The following is a description of a gene set: studied in species Homo sapiens Human Gene Set: chr7q31, and this is the list of marker genes: RNA5SP239, RNF133, CPED1, HYAL6P, GTF3AP6, RNF148, RNA5SP240, PNPT1P2 (polyribonucleotide nucleotidyltransferase 1 pseudogene 2), ASZ1, ZNF800, LAMB4, FOXP2, ENSG00000241345, PIGCP2, AASS, TPM3P1, CYCSP19, THAP5, CAV2, LINC02830, MIPEPP1, FAM3C, MTND5P8, WNT16, MIR3666, NDUFA5, ZNF277, ANKRD7 (ankyrin repeat domain 7), SLC26A3, HRAT17, LINC01392, LYPLA1P1, LAMB1, EIF3IP1, RNU7-154P, MIR592, TES, BUB3P1, GRM8-AS1, RNU6-581P, RNU6-517P (NCBI Gene Id 106479795), LRRN3, FEZF1-AS1, DOCK4-AS1, SNORA25B, ENSG00000219445, GPR37, RPL3P8, LSMEM1, HYAL4, MTND4P6, POLR2DP2, CAV1, MIR6132, LSM8, DNAJB9, TMEM229A, ENSG00000237813, FEZF1, ANKRD49P4, ENSG00000288634, LINC03043, ENSG00000289578, TSPAN12, RNA5SP237, RPL7AP42, CFTR, MET, ENSG00000225647, KCND2, MTCYBP24 (MT-CYB pseudogene 24), ENSG00000243574, ENSG00000225457, MTCYBP6, PPIAP93, SLC13A1, RAC1P6, RN7SKP187, RNU6-296P, SPAM1, ASB15, POT1-AS1 (NCBI Gene Id 402590), DOCK4, RNA5SP238, PRELID3BP10, CFTR-AS1, MDFIC, WNT2, PTPRZ1, LINC01393, COMETT, RNU1-29P, SSU72L6, LINC02903, POT1, IQUB (IQ motif and ubiquitin domain containing), ST7-OT4, SMIM30, ST7-AS1 (NCBI Gene Id 93653), NRCAM, ST7-AS2, GPR85, MTX2P1, SAMTOR, RN7SKP277, CAPZA2, ENSG00000298840, LMOD2, EEF1GP1, NPM1P14, PNPLA8, RPL7P32 (ribosomal protein L7 pseudogene 32), RNA5SP241, IMMP2L, ASB15-AS1, LINC03076, TMEM168, ENSG00000237870, MTND6P24, HMGN1P18, COX6A1P6, ENSG00000287568, RNU6-11P, ING3, LINC02476, RPL31P37, TFEC, ST7, CADPS2, CTTNBP2, DLD, PPP1R3A, TAS2R16, RPL31P39, IFRD1, LINC03012, WASL, RPS26P31, WASL-DT, GRM8, RPL36P13, RNU6-102P, ZNF277-AS1 (NCBI Gene Id 124901728)